Given this list of marker genes SLC15A4, SLC25A29, SLC7A1, SLC38A5, SLC38A3 (NCBI Gene Id 10991), SLC66A1, here is a description of the gene set: The directed movement of L-histidine across a membrane. Human Gene Set: GOBP_L_HISTIDINE_TRANSMEMBRANE_TRANSPORT studied in species Homo sapiens